Given this list of marker genes C17orf75, SURF6, ASCC1, NR1H2, MBTPS2, TUBGCP3, MRPS31P4, PLEKHG2, ZNF276, RSPO2, RBM42, MFSD4A, NDUFA13 (NCBI Gene Id 619501, NADH:ubiquinone oxidoreductase subunit A13), MARK4, ZNF227, THEM4, OBI1, POLR1F, RPL38, SUGCT, GARS1, PPP6R1, TLE6, GFM2, LINC02210, SUPT5H, U2AF1L4, NPLOC4, ADPRM, SCO1, ZBTB40, NAPA-AS1, ENSG00000232995, DNAJC25-GNG10, RABGAP1L, B4GALT3, PKD2L2-DT, SIRT4, MCAT (malonyl-CoA-acyl carrier protein transacylase), DHX33-DT, NSL1, HYCC2, PSMF1, MATR3, CCAR2, TSSK6, COPS7B, DNAJC25, LINC01600, PDE6D, LYSMD1, CDC42SE1, SETDB2, KRTDAP, PLCB4, STX18-AS1, SLC39A3, CCDC59, SPAG8, CTNNB1, LRRC37A5P, EIF1AD (eukaryotic translation initiation factor 1A domain containing), CACYBP, GABARAP (NCBI Gene Id 201246), STAT1, KDM5C, RPL36, AARS2, ZMYM4, NDUFAF4P1, NSUN6, FZD1, ZNF391, FRA10AC1, TRIP4, RNU7-27P, CCDC88A, EDC4, MTMR9, H2BC15, COQ4, ZNF461, MIR548AL, MRPS18C, LCDR, GSTCD, PPIL3, PRRG2, NR2F1, CBLL1-AS1, PROX1, RNF207, NUP155, RPS7, ZNF302, MNAT1, GTPBP3, MINPP1, DDX41, SRP9, NDUFB3, SEC22B, TMEM41A, SPOCD1, CIAO3, TMEM267, SV2B, ZBTB45, ZNF582-DT, CAB39L, RPL26L1-AS1, MMACHC, HDGF, COASY, SCARNA2, MRPS34, WDR11, CCDC77, CBX3, PEX13, MTF2, RNVU1-14, ARMH3, GAS6-DT, ZNF581, SNRPD3, KANSL1 (KAT8 regulatory NSL complex subunit 1), SSBP1, RRP15, SNAP23, TP53, ADAP2, HLA-DMA, MIR1302-3, CDK5RAP1, HMGB1, ZNF689, CSTF2T, ARL5B, ATF7IP, THAP10, METTL15 (NCBI Gene Id 196074), UBE2F-SCLY, KRR1, AIFM1, SLC27A5 (NCBI Gene Id 22942), TBL3, VTRNA1-3, NME1, OGT, STX18, YJU2, YBEY (ybeY metalloendoribonuclease), STOML1, ENPP3, HIRA, TOP3B, CENPBD2P, ADPRHL1, TPRKB, GTF3C5, WDR89, EPS15, ZNF225, CHD9, ADGRL1, EME2, TOR1AIP1, BRD2, ZNF490, MRPS31, LINC00652, MRPL40, TACO1, ALG10B, ZNF569, CASP7, WDR31 (NCBI Gene Id 114987), CFAP20, ABCE1, MRPL44, POU2F2, SUPT7L, H3C9P, SERP1, MAN2C1, TTC4, DUS1L, CCDC32, SMG8, TUBA1B-AS1, VARS2, ALOXE3P1, ZNF131, JMJD4, ARMT1, MRPL39, HEXIM2-AS1, BUD31, SLC26A11, ABCC5 (ATP binding cassette subfamily C member 5), AGK, ADPGK, IFT56, CLIP1, AURKAIP1 (aurora kinase A interacting protein 1), USPL1, GARS1-DT, CCDC163, NUP43, MRPL1, HEXIM2, FBXO7, ZER1, CGGBP1, EXOSC3, BBS1, NCBP3, INTS5, SREK1IP1, KDM5A, ISY1-RAB43, PKD2L2, WDR36, PAFAH1B3, EML2, DNAJC6, COMMD2, XIST, CASTOR1, FAM185A, GLUD1P3, SMG7, TTC38, MIR7-3, SCNM1, VPS51, ANAPC10, MPHOSPH10, PGM2L1, LRP3, DRG2, B3GAT3, WRAP53, TATDN3, DDX55, ASB16-AS1, NOXA1, MED18, SIL1, NOP16, CCNC, TOB2, GHET1, GUK1, TIMM29, WDR24, NDUFA12, TPM3, DTWD1, PEX3 (NCBI Gene Id 8504), INO80C, DDX51, NME1-NME2, POLR3B, RNU5E-6P, PRPSAP2, MRPS18B, PCID2, PCBP2 (NCBI Gene Id 5094), SMARCD1, CFAP418, GABPB2, ARL1, DPP9 (dipeptidyl peptidase 9), LINC01547, DCXR-DT, GNB2, CALM2, LINC02210-CRHR1, RNY1, MCEE, COMMD9, RPS2 (ribosomal protein S2), ZNF233, MTND5P11, NDUFC2-KCTD14, VPS9D1, GTF2H4, C3orf38, MRPS31P5, TRAF6, FAN1, METTL9, SLC24A1, GET3, BMS1P4-AGAP5, ELFN2, MPLKIP, MICAL3, C12orf76, STAT3, RPL8, HINT3, LZIC, UBE2F, DHX33, SLC4A1AP, RNVU1-27, NOSIP, LINC01775, RNVU1-15, PSTK, KBTBD4, LSG1, TRIM59, FAAH, GEMIN7, LINC01232, CIB1 (NCBI Gene Id 10519), YIPF2, AAR2, PCLAF, DMAP1, DCP1A, NIF3L1, ALG10, INTS12, THUMPD3-AS1, WEE2-AS1, NSA2, LRRC49, SSBP2, STAT4, KDSR, TMEM101, SNHG17, ATN1, ZNF791, EXOC2, CENPU, PFKM, DPY19L4, PLEKHM3, ING4, VPS36, ZNF582, KPTN, VPS13B, VPS13B-DT, EPCIP-AS1 (NCBI Gene Id 54067), BMS1P4, PRDX5, SENP1, WDR70, AGBL5-AS1, NOC4L, WDR83, SNORD68, CWC27, RALGAPB, ZNF106, VPS25, CAPS2, RMND1, MDH1, JPX, MED9, TMEM40, EIF4E3, MTIF2, PRSS27, COX16, RAG1, PSENEN, SGF29, VTA1, GFI1, PML, FAM98B, MED23, H2AC15, NUF2, STX16, CBLL1, MIR7-3HG, ZNF580, GTF2B, PUS10 (pseudouridine synthase 10), ADAT2, PPFIA3, SNORA78, NDUFAF1, C6orf226, ZFP14, SNHG9, NACA, HNRNPA2B1, RTTN, TUT1, DDN, MZF1, ANAPC5 (NCBI Gene Id 51433), MCM3AP, DSTYK, GALK2, USP30, WNT2B, WDR11-DT, NDUFC2, MTRF1, PRMT5, MAP3K7, PRECSIT, RPL26L1, RNVU1-6, BPNT1, IPO4, ALKBH3, AGK-DT, EIF3F, C19orf53, ZNF165, PSORS1C1, TBC1D19, PIGL, FAM227B, NSFL1C, ENSG00000278356, NUDT3, SF3A3, MRPS16, RNF216P1, NUP107, ISY1, ITGB3BP, LINC00680, PRMT5-DT, RBM28, RNF6, CDC16, RNASE11, AP3S2, ANO8, ZNF688, PCAT6, INTS14, TMUB2, SELENOH, MITD1, PPP1R10, GPC6, SMARCD2, C10orf88, RAB2B, PLK1, NMNAT1, RBBP5, GTF3C3, GUCD1, TSPAN10, MLEC, SAR1B, DNAJC10, GBA1, NDUFS3, CUL4A, NDUFS7, HELQ, THUMPD1, KCTD5 (potassium channel tetramerization domain containing 5), SFSWAP, TRUB2, WWOX, AGBL5, NORAD, TVP23B, BMS1, SLX9, TRMT112, SETD5, TUBA1B, SLC33A1, WDR83OS, ZCRB1, H4C3, NKAP, TMEM79, LAS1L, PSMB6, TBC1D31, ZNF282, ZNF579, ACTR3, VTRNA1-2 (NCBI Gene Id 56663), RAI1, PPHLN1, EFCAB7, EXD3, MRPL48, TMEM259, ZNF570, ADRA1A, LINC01719, BRF2, ITFG2-AS1, MRPS23, KDM1A, PRR3P1, PROX1-AS1, TMEM242, DCXR, SLC39A13, SNAP47, TMEM242-DT, PAXBP1, CYP1A1, METTL25 (NCBI Gene Id 84190), KLHL22, ANKRD13A, ZNF775, BUB1B, COPS2, UBB, TOX4, RPL13, TJP3, NUP107-DT, TEFM, MRPL30, DDIT4, MTCO3P12, PAFAH2, UTP3, ZNF221, STX16-NPEPL1, PDE4A, KNL1, SMG5, TARS2, NKAPP1, FEM1B, SMG7-AS1, GINS3, GADD45B, SNRNP27, ZNF225-AS1, RGS5, BANF1, CCNL1, RNF207-AS1, RNU6-2, WDPCP, here is a description of the gene set: Genes containing one or more binding sites for (ZNF784) in their promoter regions (TSS -1000,+100 bp) as identified by GTRD version 20.06 ChIP-seq harmonization. from publication Yevshin I, Sharipov R, Kolmykov S, Kondrakhin Y, Kolpakov F (PMID 30445619) Human Gene Set: ZNF784_TARGET_GENES studied in species Homo sapiens